Given this list of marker genes SERPINF1, SLC2A4, SLC8A2, TREM2 (NCBI Gene Id 54209), CHRNA7 (cholinergic receptor nicotinic alpha 7 subunit), APP, MAPT, ATXN1L, ADGRF1, ABCA7, ADCY8, SCN2A, PTN, JPH3, S100B, TH, SHISA7, PAK5, FOS, INSR, LMX1A, GRIN2A, DRD1, ADCY1 (adenylate cyclase 1), PAK6, RCAN2, GIP, KCTD16, DRD2, SLC6A1, MECP2, SYT11, NTF4, SRF, LRRN4, SGK1, PGRMC1, FOXO6, DCAF11, B4GALT2, KLK8, ITGA8, CIC, PAIP2, CREB1, RGS14, LGMN, CPEB3, SORCS3, VLDLR, TAC1, SLC24A2 (solute carrier family 24 member 2), NFATC4, FEN1, CHRNB2, ITGA5, SHANK3, CAMK4, ATXN1, BLOC1S6, KAT2A, CSMD1, TUBA1A, SLC8A3, ACSS2, GRIA1, SLITRK4, CTNS, OXT, COMT (NCBI Gene Id 1312), ASIC1, CALB1, CRTC1 (CREB regulated transcription coactivator 1), KCNK2, SLC17A7, PRNP (prion protein (Kanno blood group)), ABCC8, C14orf28, CEBPB, NTAN1 (NCBI Gene Id 123803), YTHDF1, LARGE1, RASGRF1, ARC, CUX2, SHANK1, PTCHD1, RCAN1, HRH1, CCND2, EIF4EBP2, BRINP1, HTR2A, NPAS4, PLCB1, ITPR3, DBH, KAT2B (NCBI Gene Id 8850), PSEN1, MUSK, BTBD9, EIF2AK4, LCN2, CEBPA, ITGA3, VPS13B, KCNK4, TACR1, FGF13, PLK2, SYT4, SLC6A4, APOE, CHST10, MDK, MAP1A, DTNBP1, TTC36, PJA2, CAMK2N1, TAFA2, LDLR, SLC1A1 (NCBI Gene Id 6505), ATAD1, ADNP, RELN, ROGDI, SPG11, PPP3CB, NETO1, GABRB3, here is a description of the gene set: The activities involved in the mental information processing system that receives (registers), modifies, stores, and retrieves informational stimuli. The main stages involved in the formation and retrieval of memory are encoding (processing of received information by acquisition), storage (building a permanent record of received information as a result of consolidation) and retrieval (calling back the stored information and use it in a suitable way to execute a given task). species: Homo sapiens Human Gene Set: GOBP_MEMORY